The following is a description of a gene set: Any process that results in a change in state or activity of a cell or an organism (in terms of movement, secretion, enzyme production, gene expression, etc.) as a result of a vitamin D stimulus. Mouse Gene Set: GOBP_RESPONSE_TO_VITAMIN_D species: Mus musculus, and this is the list of marker genes: Sfrp1, Prkcb, Fgf23, Snw1, Trim25, Trim24, Alpl, Spp1, Ptgs2, Tnc, Bmp7, Gprin3, Gdap1, Snai2, Kl, Pdia3, Abcb1a, Tyr, Mn1, Cyp24a1, Stc2, Pim1, Tgfb1, Stc1 (NCBI Gene Id 20855), Casr, Med1, Fes, Cdkn2d, Cyp27b1, Kdm6a, Vdr, Rxrb, Penk, Phex, Tpcn2 (NCBI Gene Id 233979), Kank2, Rxra